The following is a description of a gene set: studied in species Mus musculus A spindle that forms as part of mitosis. Mitotic and meiotic spindles contain distinctive complements of proteins associated with microtubules. Mouse Gene Set: GOCC_MITOTIC_SPINDLE, and this is the list of marker genes: Kif18a, Wapl, Stag1, Rae1, Tfdp2, Kat2b, Dr1, Dcdc2a, Capg, Taf1d, Rmdn3, Mak, Rps3 (NCBI Gene Id 52418), Cttn, Eml4, Efhc1, Agbl5, Diaph1, Atat1, Rcc2, Nedd9, Poldip2, Ska1, Tubb6, Sgf29, Cdk1 (cyclin dependent kinase 1), Cdc14b, Katna1, Dlgap5, Dctn1, Nsmce1, Dynll1, Cdc16, Misp, Adrb2, Neil2, Map1s, Ccsap, Tada3, Racgap1 (Rac GTPase-activating protein 1), Ngrn, Lzts2, Cdc7, Aurkb, Tubb4a, Eml2, Flcn (NCBI Gene Id 216805), Kif20a, Smc6, Haus7, Tbl1xr1, Eml1, Gpsm2, Kif2b, Rmdn2, Arhgap6, Clasp2, Tubb3, Tpx2, Dzip1l, Ptpn7, Aurka, Eml3, Yeats2, Nup62, Hepacam2, Kif22, Haus8, Tubb2b, Spout1, Dynlt3, Nudc, Lsm14a, Tbck, Myf6, Haus2, Ccdc117, Knstrn, Pkd2, Odam, Prc1, Haus6, Ska3, Ift43 (intraflagellar transport 43), Aspm, Git1, Phlpp2 (PH domain and leucine rich repeat protein phosphatase 2), Stag2, Trat1, Wnk1, Tbl1x, Hnf4g, Mapre3, Ckap2, Sirt2, Wdr5, Kmt5b, Kifc5b, Espl1, Fam161a, Kat5, Cdc27, Nin, Anapc7, Spag5, Mapkbp1, Cdk5rap2, Or2a7 (olfactory receptor family 2 subfamily A member 7), Fam83d, Kifc1, Ncor1, Haus4, Nudcd2, Hsf1, Mbip, Pycr3, Cdc42, Bccip, Aaas, Dnaaf5, Zzz3, Tubb2a, Katnal1, Tubb1, Rmdn1, Cntrl, Ect2, Tnks, Ckap2l, Hecw2, Haus1, Tubg1, Cdc6, Tubb5, Kif11, Cenpe, Rangap1, Cltc, Arhgef7, Dnali1, Golga2, Ikbkg, Epb41, Cd180, Klhl22, Rtraf, Mapre1, Clasp1, Plk1, Slc34a1, Cxcr2, Pkp4, Tmem9, Nusap1 (NCBI Gene Id 99457), Gpx2, Pkhd1, Kif20b, Map9, Kat2a, Cul3, Smc1a (NCBI Gene Id 80490), Katnbl1 (katanin p80 subunit B like 1), Limk2, Mad2l1, Ypel5, Iqcb1, Haus5, Haus3, Kat14, Trappc14, Tppp, Tacc3, Mad1l1, Ttc28, Cdc14a, Smc3 (NCBI Gene Id 13006), Hnrnpu, Kif23, Map4 (microtubule-associated protein 4), Kif18b, Gem, Mapk1, Hdac3, Tada2a, Tubb4b, Ik, Cep295, Map10, Numa1, Tpr